The following is a description of a gene set: Genes co-regulated in uterus during a time course response to progesterone: SOM cluster 4. Mouse Gene Set: YAO_TEMPORAL_RESPONSE_TO_PROGESTERONE_CLUSTER_4 species: Mus musculus Human infertility and recurrent pregnancy loss caused by implantation defects are poorly understood. Hoxa-10-deficient female mice have severe infertility and recurrent pregnancy loss due to defective uterine implantation. Gene expression profiling experiments reveal that Hoxa-10 is an important regulator of two critical events in implantation: stromal cell proliferation and local immunosuppression. At the time of implantation, Hoxa-10 mediates the progesterone-stimulated proliferation of uterine stromal cells. Hoxa-10 mutants express a stromal cell proliferation defect that is accompanied by quantitative or spatial alterations in the expression of two cyclin-dependent kinase inhibitor genes, p57 and p15. Hoxa-10 deficiency also leads to a severe local immunological disturbance, characterized by a polyclonal proliferation of T cells, that occurs in place of the normal progesterone-mediated immunosuppression in the periimplantation uterus. from publication Yao MW, Lim H, Schust DJ, Choe SE, Farago A, Ding Y, Michaud S, Church GM, Maas RL (PMID 12554760), and this is the list of marker genes: Fkbp10, Ak4, Syngr4, Galr2, Rcc2, Ybx2, Drd4, Fdps, Rgs5 (NCBI Gene Id 71800), Gcat, Iglv3, Ccdc90b, Barx1, Ldlr, Tiaf2, Mc2r, Ercc2